The following is a description of a gene set: Mouse Gene Set: GOBP_TELOMERE_ASSEMBLY studied in species Mus musculus A cellular process that results in the aggregation, arrangement and bonding together of a set of components to form a telomere at a non-telomeric double-stranded DNA end. A telomere is a terminal region of a linear chromosome that includes telomeric DNA repeats and associated proteins., and this is the list of marker genes: Pot1b, Pot1a, Tinf2, Acd, Wrap53